The following is a description of a gene set: species: Homo sapiens Human Gene Set: GOBP_PYRIDINE_CONTAINING_COMPOUND_METABOLIC_PROCESS The chemical reactions and pathways involving a pyridine-containing compound, i.e. any compound that contains pyridine or a formal derivative thereof., and this is the list of marker genes: PRKAA1, ACMSD, KMO, DERA, NUPR1, IFNG, INS, GIT1, PSEN1, IER3, OGDHL, NUDT17, ASPDH, PPARA, MLST8, PGM1, IDH1, HK1 (NCBI Gene Id 59333), UCP2, STAT3, ENO1, KYNU, GOT1, IDO2, PRKACA, AFMID, PDXP, TREX1, PGK2, PC, PRKAG3, MTCH2, SLC4A1, PFKFB1, PFKFB2, NNMT, SLC25A11, VCP, BPGM, BCL2L13, SLC25A18, ALDH1L2, PRKAG2, HK2, SHPK, HAAO, ACO1, APP, RBKS, ALPL, NCOR1, TIGAR, FMO2, FKRP, DCXR, GALK1 (NCBI Gene Id 2584), IDH2, PNP, ARL2, ALDOC, HIF1A, INSR, PRKAA2, QPRT, PFKL, ACACB, NMRK2, NOCT, ME1, HDAC4, MDH1, ENO2, EIF6, FOXK1, SLC25A12, IDO1, ADPGK, HKDC1, OGT, MDH2, GPI, PSAT1, ALDOB, TRIM63, SLC25A22, FBP1, PRKAG1, PGAM2, RPEL1, PPP2CA, SIRT6, GPD1L, PFKP (phosphofructokinase, platelet), GPD1, IGF1, KAT2B, PKM, CBFA2T3, NADSYN1, NADK2, ENO4, ALDH1L1, PGK1, PFKM, DDIT4, GCK, P2RX7, NMNAT3, OGDH, NADK, ACTN3, TALDO1, PRPS2, GAPDH, FOXK2, SLC25A13, NNT, FLCN, NAPRT, LIPA (lipase A, lysosomal acid type), TP53I3, GOT2, ENO3, NUDT12 (nudix hydrolase 12), PRXL2C, NMNAT2, MTOR, SARM1 (NCBI Gene Id 23098), MTAP, MFSD8, RPTOR, HK3, PKLR, SLC2A6, PLPBP, SLC4A4, COL6A1, NUDT13, UCHL1, TPI1, ARNT, PDXK, LDHB, NAXE, G6PD, NMRK1, ME2, PFKFB3, EP300, MACROH2A1, PGLS, PGAM4, RPE, HTR2A, NAXD, DHTKD1, NAMPT, PNPO, NOX1, NMNAT1, GPD2 (NCBI Gene Id 2820, glycerol-3-phosphate dehydrogenase 2), ZBTB20 (zinc finger and BTB domain containing 20), GAPDHS, CD38, PGD, PGAM1, JMJD8, MDH1B, RPIA, H6PD, TKT, MLXIPL, ZBTB7A, SRC, TP53, LDHA, ALDOA